Given this list of marker genes SMC3, NAA50, STAG2, NIPBL, SMC1A, STAG1, RAD21 (NCBI Gene Id 5885), here is a description of the gene set: species: Homo sapiens The process in which the sister chromatids of a replicated chromosome become joined along the entire length of the chromosome during S phase during a mitotic cell cycle. Human Gene Set: GOBP_ESTABLISHMENT_OF_MITOTIC_SISTER_CHROMATID_COHESION